Given this list of marker genes Rps4x, Rnf217, Rpl7a-ps8, Kif20b, Fam13b, Cdk5, Rny3, Zfp90, Bpnt1, Zfp608, Ift56, Fbxw17, Iars1, Adra1b, Cyth3, Lmnb1, Mir7238, Gm4524, Fmc1, Myo1c, 2610005L07Rik, Irak1bp1, Gm20618, Paxip1, Pcdhgc3, Popdc2, C1d, 2900052L18Rik, Rdh11, Ptgs2, Tmub2, 1700023G09Rik, Gpkow, Tmem67, Veph1, Slc30a9, D930007P13Rik, Chrna9, Etl4, Edn1, Rcan2, Cwf19l2, Zc3h11a, Nras, Mro, Mir6420, Usp27x, 1700023F02Rik, Ctdspl2, Gm9869, 4921513I03Rik, Zfand5 (zinc finger, AN1-type domain 5), Gm20743, Tulp4, Anapc5, Gm11228, Dnaja1, Suco, Ppp1r9b (NCBI Gene Id 217124), Mtmr9, Cnot6l, Rps18-ps4, Fnbp4, Zbtb20, Slco5a1, Sdk2, Gm8079, Gm24793, Mon1b, Slc39a10, mt-Tl2, Gpr19, Mia2, Tmem69, Atp13a4, Igf2r, Mir677, Gm28578, Rpl5, Ccni, Gm11517, Cxxc1, Pan2, Tlcd1, Ercc4, Eif2b2, Cdkn2c, Coq6, Gm14455, Gm25323, Eef1akmt1, Ilf2, Gm23205, Mrpl14, Csgalnact2, Itga9, Gm24998, Dnajb4, Nufip2, Zbtb38, Nt5dc2, Fpgs, Vcp, Onecut2, Cnpy2, Hsd17b7, Alkbh5, Epc1, Pisd, Misfa, Lipt1, Prkrip1 (Prkr interacting protein 1 (IL11 inducible)), Tbxas1, Gm20471, Mir7224, Zfp365 (zinc finger protein 365), Pde4b, Tmem106c, Jarid2, Cul5, Atp5f1b, Rad51b, Gm40038, Txnrd1, Gm23220, Col4a5, Gm13974, Uhmk1, Gm9929, Zc3h7a, Tspan9, Slc5a6, Tha1, Gm25930, Stk35, Cbarp, Rpl10-ps2, Fis1, Snord92, 2810454H06Rik, BB557941, Taf5, Ift57, Zcchc8, A930007I19Rik, Asb4, Sclt1, Rps27l, Gm4734, Qars1, Gckr, Msl2, Akap17b (NCBI Gene Id 338351), 1700041I07Rik, Trmt2b, Gcn1, Pde4a, 2810039B14Rik, Nmnat2, Inpp1, Palld, Tcte2, Klhl12, Usp12 (ubiquitin specific peptidase 12), Gm14215, Gm12915, Rny1, Tinf2, Ndufs7, Tcf4, Tnk2, Gm26403, Rptor, Tbc1d20, Ddx19a, Pja1, Tent4b, Uncx, Gm14207, Gm26802, Fgf7, Gm16041, Fgl1, Ppp6r3, Cnksr3, Mir6359, Arhgap1, Atp5po, Gm9905, Gm15179, Zkscan5, Gm15927 (NCBI Gene Id 102638607), Aff4, Malat1, Spata1, Prickle1, Itgav (NCBI Gene Id 76358), Folr1, Derl1 (Der1-like domain family, member 1), Mef2c, Med24, Nxf1, Rubcn, Med25, Ftx, Usp1, Tada2a, 9630013D21Rik, Fus, Snhg6, Knl1, Ift70a1, mt-Ts2, Slc4a2, Gm36569, Preb, Tprg1l (transformation related protein 63 regulated 1 like), Spsb4, Cops3, Stk4, Rapgef2, Ankrd10, Ptges3l, Gm11816, Kdsr, Zfp58, Pdia3, Rps3a1, Mocs2, Sh3gl1, Tmem198b, Arf4 (ADP-ribosylation factor 4), 2310026L22Rik, Fgf9, Gm3489, Hnrnph3, Cuedc1, Aknad1, Skic3 (NCBI Gene Id 218343), Nifk, Yars1, Skida1, Tcerg1, Smarca5, Rps5, 4833439L19Rik, Rcor1, Atp8a1, Nckap5 (NCK-associated protein 5), Dnai2, Gm12536, Gm6313, Bet1, Wac, Zmym4, Aox4, Cox7a1, C030037D09Rik, Ptch2, Arl2bp, R3hdm1, Bcas3os2, Gm12415, Dcun1d4, Pdha1 (NCBI Gene Id 18597), Rsrp1, Slc39a6, Cdk2ap1rt, Fntb, Cep126, Smarce1, mt-Nd5, Gm9924, Tnrc6a, Tm9sf4, Akr1a1, Ttc17, Ctnnd1, Commd1, Baalc, Rps8-ps3, Ifi203, Snx1, Fut10, Ccdc80, Wdr26, Fmo2, Gnai3, Tars1, Atp6v1c1, Ranbp9, Gm26021, Gm15477, Mir1949, Hjurp, Gm5602, 5730480H06Rik, Pkn2, Ifi203-ps, Pfkfb3, Cpeb3, St7l, Fryl, Ip6k2, 4921508M14Rik, Ankrd40, B230216N24Rik, Ogdh, Snx15, Kxd1, Zfp945, Pecam1, Atp2a2, A530020G20Rik, Slc39a13, Riok3, Sox9, Gabpb1, Gm15895, Rnu11, Bcl6 (NCBI Gene Id 12053), Clasp1, Ugdh, Sdf2l1, Pde7b, Cnot3, Gm10655, Alkbh3os1, Mfap3l, Gm16759, Gtf3c6, Gm22546, 2810002D19Rik, Cryz, Cipc, Chd2, Clspn, Tbcel, Hexim2, Hmga1, Arhgap4, Nucks1, Bola2, Fndc7, Nek9, Wdr11, Wincr1, Stk38 (NCBI Gene Id 77222), Sik2, Crebzf, Kntc1, Zbed3, Bcar3, Snord3a, Snrpb, Timm9, Chrna1, Srr, Il6, Elapor2, Pgap2, 4933431K14Rik, Opn3, Mttp, Gga1 (golgi associated, gamma adaptin ear containing, ARF binding protein 1), Rnf128, Rufy1, Serinc4, Srpk2, Apon, Ccz1, A730013G03Rik, Mycbp, Prpf4b, 4930453N24Rik, H4c14, Dio2, Mc4r, Sertad2, Nepro, 4930540M05Rik, Emilin1, Lsg1, Ccdc102a, Zbed6, Col4a6, Nfu1, Arl1, Paip2, Ctr9, Mtif3, Ccng2, Naa10, Dlx2, Pkig, Cdc7, Gm16062, Shc4, Odf2l, Gstcd, Wdr64, Tg, Prdm9, Tti2, Apc, Ldha (lactate dehydrogenase A), Rdm1, Zfp3, Gdf5, Vwa8, mt-Th, AI987944, Cdc16, Tlr1, Nfic, Depdc5, Mrnip, C230035I16Rik, Zbtb18, Mir207, Fmo1, Yars2, Gm12295, Map3k7cl, Sema3a, Has2, AI480526, Gm15941, Tpx2, Leng8, Phf19, Map2k5, Sp1, Mrps6, Mir7074, Niban1, Gm12974, Lsm2, Pou1f1, AU015336, Ccdc162, Gm13652, Gm42814 (NCBI Gene Id 115489721), Tshz1, Greb1l, Tesk2, Tram1l1, 1700122E12Rik, Six2, Dync2i1, Mir7687, Birc6, Epha7, Clvs2, Mrfap1, Btbd3, Gm3716, Rab8b, Naaa, Mir99ahg, Kat2b, Sema4b, Coq3, Asb3, D3Ertd751e, Morf4l2, P3h2, Dbf4, Mfsd2a, Brd4, 2310058D17Rik (RIKEN cDNA 2310058D17 gene), Fuca1, Nt5m, Prdx2, Fgd4, Fkbp8, Gm16364, Orc2, Phldb1, Atp6v0a1, Gadd45gip1, 5930403N24Rik, Crem, Gm14216, Tph1, Stxbp3, 1810010H24Rik, Npepps, 4930528P14Rik, Sptlc2, Dnajc13 (DnaJ heat shock protein family (Hsp40) member C13), Phf12, Hspa13, Mir1931, Gm27003, Rrm1, Rxfp4, Npr1, Trim11 (tripartite motif-containing 11), Marchf8, Adgrl2, Sec31a, Tmem119, Slc23a4, Hmgxb4, Fam234b, Tnfaip8l2, Scn2a, Slc39a14 (NCBI Gene Id 213053), Afg3l1, Dennd11, Myo7a, Zfp131 (NCBI Gene Id 72465), H3c6 (NCBI Gene Id 319151), Wt1os, Tedc2, Obi1, Clcn3, Gm13446, H6pd, Ubtf, Gm10441, Nus1, Tbce, Gm13840, Tbl1x, Stk33 (NCBI Gene Id 74040), Abraxas1, Nup54, 2600014E21Rik, Serpinb2, Runx2os2, Neat1, Tmem259, Ncam1, Enho, Fcsk, H2bc6, Mbnl1, Nrep, Rsrc1, Otud4, Poc5, A730049H05Rik, Acmsd, Usp47, Cyp51, Oit3, Pcm1, Enthd1, Idh1, Mosmo, Gm29340, Tatdn2, Gm13856, Gm23699, Oga, Capns1, 1700113A16Rik, Trim24, Zfp408, Slc5a3, Rundc1, Samd10, Cflar, Prkg2, Osgin2, Immt, Washc2, Gemin5, Gm11398, Mrps31, Slc25a25, Ttc32, Unc13b, Eomes, Efcab7, 4933421A08Rik, 1700016A09Rik, Mir3109, Zbtb11os1, Gm15541 (NCBI Gene Id 105242887), Zfp207, Cp (ceruloplasmin), Slc45a4, Zp1, Abtb3, Arcn1, Slc12a4, Med18, Omd, Zfp281, Sacs, Milr1, Fam110b, Sema3d, Steap1 (six transmembrane epithelial antigen of the prostate 1), Zfp36l2, Dhx34, Rmnd1, Myd88, Ufl1, Tcf12, Lmbrd1, Zfyve26, Hdac9, Bhlhe22, Snx12 (sorting nexin 12), Bnc2, 9330136K24Rik, Vps11, Snord13, Otx1, Itga6, Rpl37rt, Mndal (myeloid nuclear differentiation antigen like), Hp1bp3, C130083M11Rik, Ahcyl2, Zfp354b, Sash1, Dusp16, Gm17308, Scamp2, Gm18303, Shox2, Zfp652, Dbi, Thrap3, Mir30a, Ssbp1, Gm12439, Ypel4, Dipk1a, Fggy, Gss, Slc35f5, Tbc1d8b, Nfatc3, Tdg, Pole3, Marcks, Bod1, Calm1, Asxl2 (NCBI Gene Id 75302), Gnb1, Lrrfip2, Elk1, Gm5614, Wdr62, Gm11917, B130055M24Rik, Spg11, Mpp4, Slc30a3, Tle3, Lrig1, Gm10222, Hdlbp, Nek7, Rabgef1, Rsrc2, Trak2, Pelo (NCBI Gene Id 105236), A430093F15Rik, Sptbn1, Nectin3, Snord59a, Fam107b, Blmh (bleomycin hydrolase), Nicn1, Echs1, Vma21, Fabp4 (fatty acid binding protein 4, adipocyte), Arsk, Azi2, Mir199a-1, Cpn1, Arhgap11a, Atf6, Hnrnpd, Rdh5, Ncoa4, Hoxc6, Tnks1bp1, Med6, Nbdy, Flcn, Csmd3, Myadml2, Uba2 (NCBI Gene Id 53913), Tecr, Fam185a, Akr1c14, Mid1, Zfp521, 1200007C13Rik, Aftph (NCBI Gene Id 75762), Tbx3os2, Nmnat3, Gm4925, Lpar1, Gatad1, Hypk, Tnrc18, Rph3al, Rtl8a (retrotransposon Gag like 8A), Golgb1, 4933417C20Rik, Baz2b, Gm17196, Gm22656 (predicted gene, 22656), Afmid, Mettl26, Elmo1, Mir100hg, Gm23034, Slc10a6, Zfp706, Ifi47, Actn4, Hip1, Hsd17b12, Eaf2, Atp5f1d, Fzd2, Zfp949, Acaa1a, Ptgr2, Gtf3a, here is a description of the gene set: Genes containing one or more binding sites for (Prop1) in their promoter regions (TSS -1000,+100 bp) as identified by GTRD version 20.06 ChIP-seq harmonization. from publication Yevshin I, Sharipov R, Kolmykov S, Kondrakhin Y, Kolpakov F (PMID 30445619) Mouse Gene Set: PROP1_TARGET_GENES studied in species Mus musculus